The following is a description of a gene set: Human Gene Set: GOBP_HETEROTYPIC_CELL_CELL_ADHESION The attachment of a cell to a cell of a different type via adhesion molecules. species: Homo sapiens, and this is the list of marker genes: RNASE10, ADIPOQ, VCAM1, FGB, MADCAM1, MIR221, IZUMO1, ITGB1, PERP, LILRB2, DSC2, ITGAX, FLOT1, ITGAV (NCBI Gene Id 7449), CEACAM6, TNF, PKP2, DSP, JUP, FGA, CD1D, MYADM, THY1, NRCAM, CTNNA3, ITGAD, SIRPA, FGG, WNK1, BMP7, IL1B, PARVA, DSG2, ITGB2, ITGB7, ITGA7, IL10, CXADR, NINJ1, ITGA4, SKAP1, AGER, CD58, CD2, ITGAM, MAPK7, LCK (LCK proto-oncogene, Src family tyrosine kinase), APOA1, JAM3, KLF4, CD200, MBP, ITGA5, MAP2K5, ITGB3, GCNT2, CD47, CD200R1, GLDN, IL1RN, CD44, PTPRC, FLOT2